Given this list of marker genes Nfia, Sox1, Otx2, Nfib, Gli2, Foxa2, Dll1, Dbx1 (developing brain homeobox 1), Nkx6-2, Isl1, Lhx3, Gli3, Sox9, Esrp1, Pou3f2, Ascl1, Isl2, Nkx6-1, Hoxc10 (NCBI Gene Id 209448), Ntrk3, Gsx2, Dmrt3, Myt1l, Mnx1, Six1, Atoh1, Fkbp8, Pou4f1, Hoxd10, Pax6, Smad4, Evx1, Olig3, Lbx1, Shh, Nfix, Lmo4 (NCBI Gene Id 16911), Foxa1, Eya1, Tlx3, Ehmt2, Sufu, Dmrta2, Fev, Tbx1, Nkx2-2, here is a description of the gene set: species: Mus musculus Mouse Gene Set: GOBP_NEURON_FATE_SPECIFICATION The process in which a cell becomes capable of differentiating autonomously into a neuron in an environment that is neutral with respect to the developmental pathway. Upon specification, the cell fate can be reversed.